Given this list of marker genes VAV1, ADRA1D, RASGRF2, FGD4, ARHGEF35 (NCBI Gene Id 445328), GNA12, GNGT2, RHOA, GNG3 (NCBI Gene Id 2785), PLEKHG5, ROCK2, ARHGEF9, ADRA1A, ROCK1, RHOC, ITSN1, PLXNB1, GNG11, MCF2, GNG2, SOS2, ECT2, ARHGEF4, OBSCN, ARHGEF26, GNG10, GNB3, ARHGEF11, GNB2, ARHGEF40, ARHGEF3, ARHGEF10L, VAV2, SOS1, TRIO, GNB1, AKAP13, GNB4, GNGT1, TIAM2, ARHGEF18, ARHGEF1, ADRA1B, NET1, GNG4, BTK, FGD2, ARHGEF39, NGEF, ARHGEF38, ARHGEF37, PLEKHG2, ARHGEF15, TBXA2R, GNG7, FGD1, KALRN, GNG13, MCF2L, FGD3, VAV3, ARHGEF17, GNA13, ARHGEF12, ARHGEF5, ARHGEF7, ABR, TIAM1, RHOB, GNG5, ARHGEF19, GNG8, ARHGEF33, ARHGEF16, GNB5, ARHGEF2, ARHGEF6, ARHGEF10, PREX1, GNG12 (NCBI Gene Id 55970), here is a description of the gene set: G alpha (12/13) signalling events Human Gene Set: REACTOME_G_ALPHA_12_13_SIGNALLING_EVENTS species: Homo sapiens